The following is a description of a gene set: Genes down-regulated in comparison of CD4 dendritic cells (DC) versus CD8 DCs. from publication Edwards AD, Chaussabel D, Tomlinson S, Schulz O, Sher A, Reis e Sousa C (PMID 12816982) The functional relationships and properties of different sub-types of dendritic cells (DC) remain largely undefined. We used a global gene profiling approach to determine gene expression patterns among murine splenic CD11c high DC subsets in an effort to better characterise these cells. species: Homo sapiens Human Gene Set: GSE339_CD4POS_VS_CD8POS_DC_DN, and this is the list of marker genes: FCGR2B, TUBB6, MFSD14A, GCLC, NBEAL2, MRAS, CXCL10, ELOVL2, NEK6, TOX4, PDE1B, KCNA7, ADAM8, NET1, REEP5, BRK1, CRIP1, RPN2, USO1, CD8A, PLEKHO1, NUDT9, TXNDC17, EIF1AY, LARP1, PTOV1, MYCL, H3C14, ARL6, VPS29, LITAF, TUBB2A, KMT5A, THAP4, CCDC12, TRPC5, UNC50, ACYP1, TIMP3, PDCD6, DDOST, MPEG1, PLEKHA5, NSDHL, CUL4A, RASD1, STX3, CLDND1, PPP1R2P1, HSP90B1, SOWAHC, FKBP1A, ODC1, RNF20, SEC61B, SNX3, ACADL, NLK, SEC61A1, PDXDC1, CMTM7, HELLS, ITGAE, PIP4P2 (phosphatidylinositol-4,5-bisphosphate 4-phosphatase 2), RNF141, CNPY2, SGK1, SERPINB2 (serpin family B member 2), ATP1B3, NPNT, SCARB2, CASP6, ERP44 (endoplasmic reticulum protein 44), TXN (NCBI Gene Id 7295), CAT, CALR, HIPK2, MXI1, HSPA5, CREG1, SLC35E4, NIP7, AKTIP, NPHP1, TBC1D23, STBD1, TSPAN32, HOMER3, XCR1, B3GALNT2 (NCBI Gene Id 148789), ITGA8, FBXL15, VWF, PKIB, WDR43, STX12, RPS27L, SMAD2, PDIA3, DNAJC10, UMPS (NCBI Gene Id 7372), IRF8, FRMD6, PSMD14, UBAC1, B3GALT1, PLEKHB2, SLK, GJC1, MYB, AHNAK, KRT18, OXCT1, NDEL1, RPL13A, ATP6V1H, PLPP1, KCMF1, ZDHHC9, ITGA6, KIF2A, ARID3B, SLC25A17, RPN1, AGPAT3, CXCR3, HSPE1, PSMB1, PMPCB, SEC63, AKR1A1, PGAM1, HCN1, FKBP1B (FKBP prolyl isomerase 1B), SLC12A7, MRPS15, ACR, TRAM1, HTR7, PI4K2A, DTNB, PFKP, ELOA, BCL2L2, ARID2, BMP8B, SEMA4A, LRRC59, MANF, SYNRG (NCBI Gene Id 11276), CTBP2, LANCL2, MICOS10, QNG1, HSPD1, CBR3, DKK3, HERPUD1, PTPRA, NAGA, SLC25A39, VTA1, HPCAL1, PTGIS, CSTB, SLC5A1, PLA2G12A, PSMG4, RTRAF, SERPINB9, ITPR1, FNBP1, CD86, SOD1, SLC11A1, SMYD5, ANXA10, CAPN5, TXNDC16, S100A1 (NCBI Gene Id 6271), SUMF1, PPT2, ADCY6, PHC2, PRDX2 (NCBI Gene Id 7001), ARRB1, CD2AP, PPA1, MAT2A, CENPV, CYB5R1, ZNF706, CNIH1, SLC33A1, C9orf72, GCSAM, GATM, ETF1, KRTCAP2, ITM2C